The following is a description of a gene set: studied in species Homo sapiens Human Gene Set: GOBP_DEHYDROASCORBIC_ACID_TRANSPORT The directed movement of dehydroascorbate into, out of or within a cell, or between cells, by means of some agent such as a transporter or pore. Dehydroascorbate, 5-(1,2-dihydroxyethyl)furan-2,3,4(5H)-trione, is an oxidized form of vitamin C., and this is the list of marker genes: SLC2A1, SLC2A4, SLC2A2, SLC2A14, SLC23A1, SLC2A7, SLC2A6, SLC2A3, SLC2A8, SLC2A9, SLC2A10, SLC2A11, SLC2A5